The following is a description of a gene set: An increased concentration of heparan sulfates in the urine. species: Homo sapiens Human Gene Set: HP_HEPARAN_SULFATE_EXCRETION_IN_URINE Heparan sulfate excretion in urine, and this is the list of marker genes: IDS, GUSB, NGLY1, GNS, VPS33A, HGSNAT, IDUA, NAGLU, SGSH